Given this list of marker genes STAT6, TBK1, STING1, here is a description of the gene set: Signal transducer and activator of transcription 6 (STAT6) may function as a signaling molecule and as a transcription factor. The canonical activation of STAT6 in IL4 and IL13 signaling pathways is mediated by the tyrosine kinases JAK (Hebenstreit D et al. 2006). Virus-induced STAT6 activation was found to be cytokine- and JAK-independent (Chen H et al. 2011). Infection of human cells with RNA or DNA viruses resulted in an interaction of STAT6 with STING. The kinase TBK1 was shown to phosphorylate STAT6, which in turn induced STAT6 dimerization and translocation to the nucleus, leading to induction of chemokines CCL2, CCL20, and CCL26 in IFN-independent manner (Chen H et al. 2011).<p>RNA virus infection triggers STAT6 activation through STING, TBK1 and adaptor protein MAVS interaction (Chen H et al. 2011). part of: STING mediated induction of host immune responses species: Homo sapiens Reactome Pathway: STAT6-mediated induction of chemokines